The following is a description of a gene set: Human Gene Set: HP_PHONIC_TICS Phonic tics Tics are defined as movements or sounds that resemble physiological motor behaviors, but are typically inopportune to social context and appear sudden, repetitive, and often exaggerated. Tic vocalizations commonly termed vocal or phonic tics may include any possible sound (eg, sniffing, coughing, throat clearing, whistling, or grunting), word, or sentence and are most commonly encountered within the spectrum of primary tic disorders, as Tourette syndrome. studied in species Homo sapiens, and this is the list of marker genes: SLITRK1, GNB1, HDC, VPS13A, PANK2, SLITRK2